Given this list of marker genes Adm, Adm2, Iapp, Ramp3, here is a description of the gene set: Reactome Pathway: Calcitonin-like ligand receptors electronically inferred by orthology from the curated human pathway species: Mus musculus part of: Class B/2 (Secretin family receptors) This event has been computationally inferred from an event that has been demonstrated in another species.<p>The inference is based on the homology mapping from PANTHER. Briefly, reactions for which all involved PhysicalEntities (in input, output and catalyst) have a mapped orthologue/paralogue (for complexes at least 75% of components must have a mapping) are inferred to the other species.